The following is a description of a gene set: Human Gene Set: GAO_ESOPHAGUS_25W_C1_CILIATED_EPITHELIAL_CELLS from publication Gao S, Yan L, Wang R, Li J, Yong J, Zhou X, Wei Y, Wu X, Wang X, Fan X, Yan J, Zhi X, Gao Y, Guo H, Jin X, Wang W, Mao Y, Wang F, Wen L, Fu W, Ge H, Qiao J, Tang F (PMID 29802404) studied in species Homo sapiens, and this is the list of marker genes: FHAD1, CLXN, CFAP276, PHTF1, CCDC157, SLC27A2, SSUH2, MOB1B, AARS2, ARL13B, DALRD3, ABCA13, DNAH1, IFT70A, WDR5B, SLC25A29, TGM3, KIAA2012, SYBU, DHRS9, DCDC2, CXXC4, CDHR3, DNAH11, DNAI3, KCNB1, RAET1E, DYNC2H1, C2CD2L, LKAAEAR1, CFAP92, RPGRIP1L (NCBI Gene Id 23322), PPP1R36, CEP162, SPATA17, RABL2A, KLF3-AS1, GJA4 (NCBI Gene Id 2701), ANKUB1, LINC01722, TUBA4B, KLHDC9, IFT80, ABCB10, ADGB, GIHCG, CEP43, TSPAN15, GPC5-AS1, CDS1, KSR1, TTC23L, PZP, CFAP44, CFAP210, TSNAXIP1, MLF1, ODAD1, LRRC61 (leucine rich repeat containing 61), IFT88, LINC03086, DNAH10, SAMD15, USP24 (NCBI Gene Id 388634), IQCH, ASTN2, IQUB, CCDC13, NPHP1, DNAI2, DGCR6, GALC, SLC13A3, LINC02345, ATXN2, EFHC1, DMPK, NPIPA1 (NCBI Gene Id 9284), WDR38, DZIP1L, MS4A8, SGMS2, IFT81, QTRT1, TRPC1, ADGRE5, CCDC103, DPY19L2P2, DNAI4, RIBC1, SAXO2, TBC1D31, IQCD, MDH1B, CFAP144, ZBBX, SLC9A4, ARHGEF38, RBM38, TTLL9, DNAH5, IFT57, RGS22, WDR90, LMLN, LRRIQ1, C16orf46, NEK10, NXF3, CFAP53, B9D1, DNAI7, ERBB4, CCN2, MLPH, DNAAF1, CCDC81, ROPN1L (NCBI Gene Id 83853), C6orf118, GPRASP3, TFF3, SDF2L1, SLC22A18, DYNLT5, ZNF674, ENPP4, DNAAF4, ANKRD54, TXNDC11, FABP6 (NCBI Gene Id 2172), RABL2B, RASA3 (RAS p21 protein activator 3), ADAP1, SNX7, DYDC2, CPEB1, NBEA, ENPP5, BASP1, DNAH7, SMPD2, ATAT1, MACF1, APCDD1, ZMYND12, TEKT2, BBS1 (Bardet-Biedl syndrome 1), SPATA4, OTUD1, PTPRT, PFN2, ZNF273, INPP5B (inositol polyphosphate-5-phosphatase B), METTL27, PACRG, C11orf16, EP300-AS1, ZNF688, SYT10, GCA, CCDC60, C8orf34, POLQ, TP73, CES4A, ECT2L, CFAP96, C12orf76, C7orf57, TCTN1, SPA17, CFAP95, KATNB1, CFAP61, KIF19, STOML3, MARCHF10, CPLANE1, CFAP300, TOGARAM2, IQCA1, CEP97, DPCD (NCBI Gene Id 25911), DNAL1 (NCBI Gene Id 83544), GAS2L2, LTBP1, TMEM67, MLLT1, HYDIN, IFT56, SSBP4, MAP9, HOATZ, SHANK2, GYG2P1, MAPRE3, FGF14, SNTN, CFAP47, SPATS1, MORN3, FBXO36, TRMT1, CFP, PRICKLE2, ZNF322, SPEF1, IFT46, CSPP1, CST6, EFCAB10, SPAG8, HHLA2, SCGB2A1, PIH1D2, NRP2, ATP2C2, ZNF440, LDLRAD1, SLC44A4, TMEM231, CFAP91, ODAD4, PTRH1, RUVBL1, C20orf96, CFAP69, MIPEPP3, CSMD1, MDM1, CD164L2, LINC00205, SPAG17, WAKMAR2, WNT16, SPAG1, RIIAD1, PSENEN, CCDC33 (NCBI Gene Id 80125), KIF6, STX7, LRRC46, MRLN, LINC02687, CCDC181 (coiled-coil domain containing 181), TSPAN19, CFAP221, NWD1 (NCBI Gene Id 284434), PRR29, FBXO31, CFAP126 (NCBI Gene Id 257177), ARMC2, WDR19, GLB1L, CHST11, DPY19L1, DTHD1, USP2, CHST9, C1orf87, PRICKLE2-AS3, IKZF4, PECR, CFAP46 (NCBI Gene Id 54777), TEKT3, CCDC78, WFDC3, RNASE4, AGBL5, MPDZ, LRWD1, KIF3A, MB, KCNRG, KIF27, SPAG6, ITGBL1, FAM174A, TIMM10B, BBS5, DZIP3, UBXN11, MORN2, BCAS3, CCDC24, ARHGAP39, ST6GALNAC2, LZTFL1 (leucine zipper transcription factor like 1), ANXA2R-OT1, CFAP299, LRRC71, LRRC74B, RITA1, AK8, DLEC1, LRIG1, TRMT9B, SPATA6L, CES1, IL5RA, ARRDC1-AS1, SIAH3, RSPH4A, GAS8, CIBAR2, SLC12A7, UBXN10, VWA3B, CROCC, APH1B, TTC16, ATP6V1C2, GOLGA2P5, LRRC27, CCDC148, DNAI1, SLC22A16, BTC, SPMIP6, FRMPD2, C5AR1, ERICH2, DNAH9, CIMIP1, KNDC1, CFAP52, SPATA18, SYTL3, WDR54, LINC02532, STMND1, CACNG6, RRAD, WARS1, PPP1R42, PTOV1-AS2, RSPH1, CCDC65, EFHB, BAIAP3, FAM81B, AGBL2, NHLRC4, PLCG2, SPEF2, NELL2, KCNMB2, PLEKHS1, CD38, CABCOCO1, RARB, PLAAT2, TTLL7, DNAH12, DNAH6 (NCBI Gene Id 79964), ARHGAP18, STX2, DCP1B, CCDC39, SNORA7B, DRC1, CAPSL, CFAP57, CFAP90, ATP6V0A4, C2orf81, FYB2, P4HTM (prolyl 4-hydroxylase, transmembrane), ECRG4, EFHC2, ARMC3, ALDH16A1, TMEM232, TTLL6, LRRC10B, CFAP20DC, SNX13, SLC7A2, TMC5, DTNA, OSGEP, PLCB2 (phospholipase C beta 2), SMPD3, CFAP43, SVOPL, CFAP54, AKAP14, ZBED4, ANKRD66, DCDC1 (doublecortin domain containing 1), ZMYND10 (NCBI Gene Id 51364), TNFRSF19, CCDC74B, RNLS, VWA3A (von Willebrand factor A domain containing 3A), FBXO15, SYNE1, PRUNE2 (prune homolog 2 with BCH domain), RSPH9, TTC21A, APBB2, TEKT4, KIF17, ALDH3B1, ANKRD18A, LRRC23, GALNS, IL20RA, SLC41A1 (NCBI Gene Id 254428), ZBED5-AS1, NEK5, TMEM45B, CLDN16, DPY19L2, ITGAL, KLHL32, STK33, ENSG00000292993, CCDC88C, TRIM37, PNO1, AP3M2 (adaptor related protein complex 3 subunit mu 2), OR7E37P, OXTR, MAPK15, SNX29, FAM227A, COL4A5 (NCBI Gene Id 1287), CCDC170, LGR4, TMEM234, TMEM151B, MAT1A, CEBPA, LINC01571, ALDH1A1 (aldehyde dehydrogenase 1 family member A1), KCNE1, CAPS2 (calcyphosine 2), SLC6A9 (solute carrier family 6 member 9), ALMS1, ARHGEF11 (NCBI Gene Id 9826), ASIC1, ENDOG, BPIFB1, USP51, UBE3D, CDHR4, CP, GLIS3-AS1, CIMAP1B, RHPN1, CIMIP2C, CCDC74A, KIF9, TMEM190, ANKMY1, NOVA1, RIBC2, AK9